The following is a description of a gene set: Human Gene Set: HP_DEVIATED_NASAL_SEPTUM Deviated nasal septum Positioning of the nasal septum to the right or left in contrast to the normal midline position of the nasal septum. species: Homo sapiens, and this is the list of marker genes: FGFR2, NONO, PAH, NF1, EP300, CREBBP, EXOSC5, PIK3CA